Given this list of marker genes PARP12, PARP6, SIRT4, TIPARP, PARP8, PARP11, here is a description of the gene set: studied in species Homo sapiens Catalysis of the reaction: L-cysteinyl- + NAD+ = H+ + nicotinamide + S-(ADP-D-ribosyl)-L-cysteinyl-. Human Gene Set: GOMF_NADPLUS_PROTEIN_CYSTEINE_ADP_RIBOSYLTRANSFERASE_ACTIVITY